Given this list of marker genes LMNA, DMD, SELENON, CAPN3, ABCD1, ANO5, ACTA1, FHL1, OPA1, here is a description of the gene set: studied in species Homo sapiens Human Gene Set: HP_HAMSTRING_CONTRACTURES Hamstring contractures